Given this list of marker genes NKG7, CEACAM1, HLA-DRB1, TNFRSF10B, RBMS3, HMGB1, PVR, CD160, PRF1, MAPK3, ABI3, PLK5, DAPK1, CD274, SPI1, CRTAM, RELA, NOTCH1, HLA-DRB3, PDCD1, GSDME, MR1, IL4I1, HAVCR2, IL12B, LAPTM5, HSPD1, AHR, CD226, FBXO38, NECTIN2, KLHL22, HRG, IL12A, UFL1, IGFBPL1, YWHAG, TGFB1, DLEC1, PRKAA1, SLC22A13, MICA, USP5, TXNIP, ADAM15, KLF4, HLA-A, NOTCH2, PRDX2, here is a description of the gene set: species: Homo sapiens Any process that results in a change in state or activity of a cell or an organism (in terms of movement, secretion, enzyme production, gene expression, etc.) as a result of a stimulus from a tumor cell. Human Gene Set: GOBP_RESPONSE_TO_TUMOR_CELL